Given this list of marker genes Nos2, Pde9a, Pde1b, Pde10a, Pde2a, Pde5a, here is a description of the gene set: Reactome Pathway: Nitric oxide stimulates guanylate cyclase species: Mus musculus electronically inferred by orthology from the curated human pathway This event has been computationally inferred from an event that has been demonstrated in another species.<p>The inference is based on the homology mapping from PANTHER. Briefly, reactions for which all involved PhysicalEntities (in input, output and catalyst) have a mapped orthologue/paralogue (for complexes at least 75% of components must have a mapping) are inferred to the other species. part of: Platelet homeostasis